The following is a description of a gene set: Genes containing one or more binding sites for (PRDM4) in their promoter regions (TSS -1000,+100 bp) as identified by GTRD version 20.06 ChIP-seq harmonization. from publication Yevshin I, Sharipov R, Kolmykov S, Kondrakhin Y, Kolpakov F (PMID 30445619) species: Homo sapiens Human Gene Set: PRDM4_TARGET_GENES, and this is the list of marker genes: CLSTN3, DSCAS, PTPRD-AS1, ARHGAP31-AS1, CAPZA2, TTI2 (NCBI Gene Id 80185), PDLIM3, STAT1, HOXB3, GLIS1, CD101-AS1, SYNCRIP, KMT2B, SLC25A53, CLTC, CCT6B, PRKD3, CXXC4-AS1, ISG15, ATP13A2, YIF1B, MIR6089, ATAD3A, AMBN, LINC02598 (long intergenic non-protein coding RNA 2598), ANKRD23, TP53I11, RBPJ, ROBO1, NAV2, KBTBD2 (kelch repeat and BTB domain containing 2), PHF20, IRX3, BBX, USP44, RAVER2, CCNE2, PSMG2, ANAPC13, ZBTB17, ZNF423, SUPT16H, DMRTA2, HSPB1, ANKRA2, ERAP1, FOXP1, NEAT1, BBS5, CDK1, RPL39P40, KCNJ2, PSMG3, ETV2, CCPG1, AKAP13, TRIM32 (tripartite motif containing 32), VIM, ZFP36L1, CARD8, SMCO2 (single-pass membrane protein with coiled-coil domains 2), UBE4B, CAPN12, SNORA17A (NCBI Gene Id 677804), MYL12A (myosin light chain 12A), DCP1A, TSPAN11, SQLE, NEURL1, MAPK14, ZNF503-AS2, AP3B1, PPAN-P2RY11, MFSD3 (major facilitator superfamily domain containing 3), SUMF2, ZNF33B (NCBI Gene Id 7582), SRSF2, COL6A1, ZDHHC24, PIK3IP1, TFAP2A, FKBP7, KLHL7, DBNDD1, GNG12-AS1, PTK6, TMEM123-DT, RPSA (NCBI Gene Id 3921), KLF13, HINT3, TTYH2, EXD2, CYP4V2, SSBP1, EFHD2, FRMD4B, MVB12A, DCAF6, KIFC2, FNDC3A, PNPLA7, TMEM123, TEN1-CDK3, RDX, CUL1, DUSP6, SCML2, ANKRD24, LAMP1, GLI3, CYP27C1, ZNF827, CTTNBP2, TSC22D4, ALPK1, SPACA6, RHBDF2, LINC00938, HNRNPU, TRAIP, ZNF335, PTPN12, TUB, HOXB9, ECM1, BTN2A1, MAFK, KLHDC9, WFDC21P, UBXN7-AS1, ENSG00000277270, DVL3, LRRC37B, NAV2-AS4, EPCIP-AS1, SQLE-DT, SNHG7, HMMR, HSPE1-MOB4, MSANTD3, H3C10, NR4A2, LIG1, HOXA-AS2, CDC42EP4, PIP5KL1, MTHFR, ECE1, HES4, PSTK, SLC41A2, ALDH1A2, CCNG2, MECOM, CCNI, RNF44, TMEM94, FZD2, TRDMT1, EFNA4, MFSD11, CDKN2C (NCBI Gene Id 654235), STX18-AS1, TMEM245, KIFAP3, MDM2, HBP1 (NCBI Gene Id 26959), MRPS18C, MFSD1, MIR1538, MED18, SELENOK, CD99P1, CEP63, KDM4B, ENSG00000263011, GAS1, EXOSC3, EFEMP1, PITX2, PTPRM, PCNX4, SLC11A2, LTBP4, NFKBIZ, LINC01275, MXI1, HOXB-AS3, DDHD2, SUZ12P1, TTF2, SAFB2, RPL7P41, TEN1, C19orf47, GET4, FBXO15, LINC01780, TBL1X, DCAF8-DT, MIR551A, ZBED3, MIIP, LINC02387, EFHC1, HOXA3, GSE1, QKI, WDR62, CARD8-AS1, ZNF503, TGFBR3, KCNK1, FHL1, E2F7, NCAM1, RPL23AP71, SPIRE1, TGIF1, ITSN1, TRIP6, SNORA17B, LNCRNA-IUR, ARHGAP24, CLCN3, GRWD1, MPP7, CMIP, PTPRD, SMG6 (SMG6 nonsense mediated mRNA decay factor), ZEB2, BACH2, SLIT2, EPB41, FALEC, NKX3-2, ATP5F1D, RNU6-920P, SERTAD4, NFIB, RAD51AP1, TAFAZZIN, DSE, PCGF2 (polycomb group ring finger 2), UBB, PSMG3-AS1, SNIP1, PRECSIT, NECTIN3, TPTEP2, MTUS1, SAP30 (Sin3A associated protein 30), MED20, SLC1A3, HES1, NPAS3 (NCBI Gene Id 64067), LAMB1, TMEM62 (NCBI Gene Id 95722), GALNT16-AS1, WDR70, ZEB2-AS1, DDX3X, PHF21A, FBLN1, ACOX1, KRBOX4, NFE2L2, POLD2, ADRA1D, KSR1, TRPS1, SSBP2, KCNJ2-AS1, DHRS12, GNG5, LINC02934, WEE2-AS1, ZNF652, SULF2, B4GALT6, MTF2, ABCF2, PDGFB, TENM4, ITFG2-AS1, LINC02615, HOXA9, IGHMBP2, CCBE1, NECTIN3-AS1, LRR1, CIRBP, TRIM41, DNAJB6, ARID2, ENC1, RNU6-1039P, CCDC85C, MCC, ASTE1, TRPC4AP, EOLA1, MIR1273C, ZBED3-AS1, CCDC102A, NRSN2, MFN1 (NCBI Gene Id 55669), ENSG00000235480, CCP110, LEISA1, BACH1, PHF2, GBA1, GNAL, HSP90AB1, STAT4-AS1, CNTNAP1, SUB1, FERMT2, NUDCD2, FUT10, KMT2D, ADAM22, EPPK1, LIMA1, PPP2R5C, PIM2, SLC35G2, ZFTRAF1 (NCBI Gene Id 50626), ELF1, TOP3B, MTCH2, EVA1B, UBE2Q1, ARL2BP, MIR615, ANKRD40, S100A11, TNRC6B, NRSN2-AS1, NEK11, JCAD, FSBP, FAT3, PPP2R5E, ENSG00000260830, PDZRN3, NDEL1, CEBPG, RPL27A, CRYBG3, UBE2D3, GAS1RR, PRSS16, MOB1A, FERRY3, CDC42EP3, LIMK1, SIX4, TNRC18, DTNA, ACTB, ATXN1 (NCBI Gene Id 7912), ARID1A, COL4A5, CRIP3, HSPE1, ENSG00000247416, MIR378H, NEDD4L, ZBTB38, TIMM21, ATAD2, DLEU1, KCND1, IGF2BP3, ADM5, DCP2, MNT, BHLHE40, PAXBP1, MSANTD2-AS1, WNK3, PTPN13, TMEM107 (NCBI Gene Id 84314), TMOD1, DLC1, AGTRAP, AVPI1, AK2, HEY2, BISPR, YWHAZ, CASTOR3P, BYSL, EMC9, IFI6, GPC5-AS1, CREM, FLJ38576 (uncharacterized LOC651430), RAB33B, RFTN1, TTC39C-AS1, FZD1, RPS29, SLC22A31, NUP98, CCNG1, SORT1, SRSF3, PRAF2, RIMS3, SPATA1 (spermatogenesis associated 1), GTSE1-DT, DDX3P2, UBE2Q2P1, HDAC1, SATB1, NDUFB10, AAAS, N4BP2, PGAP4, SAP30-DT, NDUFS7, SULT2B1, RMC1, SEC31A, CLYBL-AS2, FOXB2, ARHGAP15, PER3, WBP4 (WW domain binding protein 4), MYBL1, MNS1, MGC16275, LSR, MRPS31P4, TMEM248, EFHD2-AS1, MIR5188 (microRNA 5188), ITGB5, SET, PGAP2, SLFN5, SMAD1, VWDE, ACSF3 (NCBI Gene Id 197322), IFT140, KDSR, RPN2, C22orf31, CTDSP1, HJV, MROH8, H2BC18, RPL22P3, PYROXD1, TTC39C, ABCB6, CCDC192, EOLA1-DT, SEMA6A, UBC, TSHZ2, EYA1, LMLN, MIOS-DT, JARID2, GRAMD4, E2F5-DT, MAPK8IP2, CCDC159, INSM1, TAGLN2, MSRB1, SLC5A3, PPAN, SYNE1, CNRIP1, C5AR1, LAPTM4A-DT, ANKRD10, GPC6, E2F5, DIPK1B, FARP1, RPS26P29, ZMIZ1, USP13, BST2, RANBP9, SLC16A11 (solute carrier family 16 member 11), LINC01505, VMP1, MARCHF5, AMOTL2, FBRS, TFAP4, VLDLR-AS1, SDE2, EDRF1-DT, TMEM260, RBM39, CT75, LINC00933, HOXC4, STAG3L3, C11orf65 (chromosome 11 open reading frame 65), IFIT1, LINC00322, PTCH1, ETFDH, COL4A6, RN7SL446P, ETV5, CTDSP2, ERN1, MTFR1, UBE2N, KIAA0319, PSD3, MAPK4, GFRA3, C10orf67, FLJ13224, MRPS6, SPRYD4, RNVU1-7, GTSE1, BBS9, VILL, PGM1, ZNF608, KCNN4, NFAT5, TJP3, STRN3, DMXL1, EFNA5, MSANTD2, PGAM1P5, IER2, MTRFR, RCC1, CALHM2, PGGT1B, STX18, H2BC5, TSSK3, EXTL3, RNF122, ATAD5, CALCOCO1, HMGA2, MLLT3, HOXA10, ISLR2, TCF3 (transcription factor 3), MAD2L1BP, MRPL21, EFNA4-EFNA3, ARHGAP40, NOLC1, ZNF573, CDKN2AIP, LARP4, AZIN2, KRT18P12, TEX264, NBPF19, SOX12 (SRY-box transcription factor 12), PIERCE2, MIR4638, ENSG00000233230, MAPKAPK3, AIG1, TBC1D9, TXNDC12, SKIDA1, FAM120AOS, CCR10, TMEM72, ZNF394, VIM-AS1, GALNTL5, CHKB, STX2, MIR6076, MIR7845, LINC01231, ARHGAP32, BMPR1A, HSPD1, BRWD1, IGFL4, DYRK2, SMG8, C4orf46, SLC26A4-AS1, BTN2A2, RBL1, GRK5-IT1, HOXA-AS3, ENSG00000205414, EMP1, RPL41, NR2F1-AS1, GUSBP1, KLHL7-DT, PLD3, PJA2, POLDIP3, ADAMTS9, CD59, SPOPL-DT, CABLES1, TLE6, HNRNPH1, BMERB1, MFSD12